Given this list of marker genes Sec63, Cps1, Htt, Otc, Fh1, Agmat, Arg1, Cebpa, Nags, Prkcsh, Ass1, Pkd1, Nr1h4, Arg2, Apc, Asl, here is a description of the gene set: A nitrogen compound metabolic process that contributes to the nitrogen cycle. The nitrogen cycle is a series of metabolic pathways by which nitrogen is converted between various forms and redox states; it encompasses pathways in which nitrogen is acted upon directly, such as nitrification, denitrification, nitrogen fixation, and mineralization. studied in species Mus musculus Mouse Gene Set: GOBP_NITROGEN_CYCLE_METABOLIC_PROCESS